Given this list of marker genes GALE, IDH2, PPP1R3A, GALK2, SORD, GCNT3, PARG, NR0B1 (nuclear receptor subfamily 0 group B member 1), LRP5, SIK1, ENO1, PPP1R2P1, IDUA, TCF7L2, AVPR1B, IL6ST, SIRT1 (NCBI Gene Id 23411), MAN2C1, GALNT7, PPP4R3A, JMJD8, C1QTNF1, ATF3, PMM2, ERRFI1, PGAM4, NCOR1, LCT (lactase), PGM5, FLCN, PYGM, GSK3A, TREX1, APOD, PPARA, PFKFB1, GCK, GCKR, IDH3G, TGFB1, FBN1, SDS, DDB1, RPEL1, GLB1L3, POFUT2, GSK3B (glycogen synthase kinase 3 beta), MANBA, RORA, SDHAF3, EXT1 (NCBI Gene Id 3966), APP, CBFA2T3, ST3GAL6, ENO4, LCTL, HYAL1, B4GALT4, TFF3, ABO, PGM3, DHDH, GAL3ST3, SI, P2RX7, OVGP1, GMPPB, PFKFB4, SLC4A4, DHTKD1, MGAM, GYG2, PHKB, ERFE, ARPP19, LCMT1, PHKG2, NTSR1, B4GALT6, HEXD, ATG12, WDR45, PDHA1, BCKDK, MPI, C1QTNF3, PIGQ (NCBI Gene Id 9091), MIR103A1, PARP1, MLYCD, NR1D1, NAGPA, INPPL1, GPLD1, CHST7, ST6GALNAC5, HEXA, EIF6, HK1, PFKP, SLC2A8, GRB10, BPGM, UGP2, CD244, CHST15, PCK2, B3GALT5, AKT2, MDH2, SERPINA12, IGF1, G6PC3, SORBS1, SLC35B4, HK2, PER2, HTR2A, IRS1, FUT3, B3GALT4, TPD52L2, IER3, SLC5A2, ADCY10, NUPR1 (NCBI Gene Id 26471), FUT5, LEP, SLC3A1, PPP1CC, IDH3A, PGM2, MAN2B1, CHST2, PPP1CB, FUT6 (fucosyltransferase 6), P2RY6, ST8SIA2, C1QTNF12, ACACB, FAM3A, SLC23A2, GBGT1, MAN2A2, NAGK, PDHA2, ATF4, PPP1R3E, UXS1, PPP1R3F, EDEM2, B3GAT2, PLEK, DDIT4, NEU3, HAS1, GSTO1, GALT, RORC, ST3GAL4, CLK2, MYORG (myogenesis regulating glycosidase), AMY2A, STBD1, FUT10, ERO1A, SLC25A11, MIDN, FCSK, STAT3, PPP1R3D, CHI3L2, NCOA2, MIR195, XYLB, SLC2A3, MLXIPL, TFAP2B, AKR7A2, PFKFB2, ST3GAL2, SLC2A4, TRIM63, EDEM1, ALDH2, EDEM3, SLC2A2, BOLA3, HYAL4 (NCBI Gene Id 23553), COQ2, SLC25A13, LANCL1, PHLDA2, PYGB, ADIPOR1, ALDOB, GHRL, SLC3A2 (NCBI Gene Id 6520), G6PC1, ENO2, GAA, WDTC1, IGFBP4, LHCGR, TP53, DCXR, SLC35A2, RBP4, PDHB, MAN1A1, B4GALT2, GAPDHS, SCARB2, PPP1R2, HKDC1, GLB1L2, TPI1, BAD, GLA, B3GALT1, ST8SIA3, ST6GALNAC3, PTPN2, GANAB, PKM, RANBP2, KAT2A, NEU2, FOXO1, GDPGP1, PGAM2, GCLC, POMC, MTCH2, KAT2B, INPP5K, PLA2G4A, CHST6, G6PC2, MOGAT2, PFKL, MAN2A1, ALDOA, BRS3, PSEN1 (presenilin 1), KLB, H6PD, MOGS, NLN, CLSTN3, NNMT, PRKN, PRKAG3, GNE, DLAT, B4GALT7, SERP1, UCHL1, RB1CC1 (RB1 inducible coiled-coil 1), GYG1, LANCL2, ZMPSTE24, PGM1, ST3GAL3, FKRP, RPTOR, PGK1 (phosphoglycerate kinase 1), ALDH1B1, GAL3ST4, ST8SIA6 (NCBI Gene Id 338596), PDK3, GLB1L, GYS1, HEXB, DYRK2, ENO3, ATG3, CHST10, PTH1R, FOXK1, ADCYAP1R1, MAN2B2, GM2A, GAPDH, CHST9, ACTN3, CHST8, INSR, TNF, FABP5, FOXK2, UCP2, MIR1271, TALDO1, GNPDA2, GCNT4, PPP1CA, SLC2A6, POMK, PGLS, SLC2A1, ENPP1, PPP1R3G, GPD2, SPATA20, SRC, TREH, PCDH12, NR3C1, EP300, FBP1, ST8SIA1, PYGL, PHKA2, CASD1, MIR107, FUT7, RENBP (renin binding protein), MGAT2, ZFP92, GLB1, OTOG, PPP1R2B, RPIA, PASK, GCG, KCNJ11, PDK4, PFKFB3, SIAE (sialic acid acetylesterase, NCBI Gene Id 95985), B4GALNT1, B3GLCT, NAGA, TFF1, SLC37A4, PKLR, IGF2, ACADM, NFE2L1 (NFE2 like bZIP transcription factor 1), GK2, HK3, POFUT1, CHST4, GLO1, PRKACA, LEPR, EPM2A, HDAC4, PC, SIRT7, CRY1, TKTL1, FPGT, NHLRC1, MTOR, SESN2, PCK1, GALNT3, B4GALNT2, CLTC, CTBS, MAN1C1, CHST1, PIK3CA, SLC35A1, USF1, BCL2L13, CS, IGFBP3, PGAM1, ATG2B, IDNK, GPD1, ANGPTL3, PTH (parathyroid hormone), OGT, MOGAT3, FUT9, KCNQ1, HSD17B14, PPARD, CHIT1, FUT4, SLC4A1, SLC45A3, MLST8, RBKS, PFKM, DGAT2, GPER1, GNMT, PPP1R3C, PGK2, ATP1A2, GOT1, GSTO2, KBTBD2, TIGAR, CHST13, FUT1, ME1, SLC23A1, STK40, AMY1C, ST8SIA5, ST6GAL2, MST1, ADIPOQ, EXT2, NFKB1, NEU4, ST6GALNAC1, GIT1, AGL, ARNT, KHK, GNPTG, PDX1, YDJC, A4GNT (alpha-1,4-N-acetylglucosaminyltransferase), PGGHG, PRKAG2, RPE, AKT1, HYAL2, NPY1R, GPD1L, GALM, B3GAT1, PDK1, B4GALT1, GYS2, HAS3, GBE1, AMY1B, CHIA, GNPTAB, CRTC2, ATG2A, NPL, SLC2A5, FUCA2, PPP1R1A (protein phosphatase 1 regulatory inhibitor subunit 1A), NDST1, ADRB3 (adrenoceptor beta 3), SNCA, GABARAPL1, SLC25A10, PGD, GLT6D1, PPP4R3B, EPM2AIP1, AKR1B1, ST6GALNAC6, CHID1, P2RY1, HIF1A, FGGY, PPP1R3B, PGM2L1, MPDU1, PRKAA2, B3GALT2, GNPDA1, PRKAA1, MAN1B1, A3GALT2, TKFC, IFNG, BRAT1, LANCL3, PRXL2C (NCBI Gene Id 203335), ST6GALNAC4, PMAIP1, GUSB, SMPD3, MAN1A2, NPC1, PRKAG1, FUCA1, G6PD, USP7, SELENOS, PRKG1, SELENON, NANS, MFSD8, WDR45B, ENOSF1, B3GAT3, FUT2, OGDHL, PPARGC1A, CHST12, LIPA, PMM1, ST8SIA4, HYAL3, WDR5, COMT, ONECUT1, WIPI1, SHPK, LDHA, CHST14, OTOGL, GK5, GCGR, CHST3, ZBTB20, GANC, GALK1, MTCL2, MOGAT1, ADPGK (ADP dependent glucokinase), OMA1, MIR15B, B4GALT3, GLYCTK, ZBTB7A, ZNF692, HAS2, RUBCNL, AMY1A, IDH1, GK (NCBI Gene Id 2710), CPT1A, WIPI2, NUDT5, FBP2, HMGB1, MGAM2, IRS2, PDGFB, OGDH, PHKA1, OAS1, FUT8, PHKG1 (phosphorylase kinase catalytic subunit gamma 1), B4GALT5, MAPK14, CHI3L1, GBA2 (glucosylceramidase beta 2), COL6A1, PPP2CA, FUOM, CHST5, INS, PDK2, DERA, KL (NCBI Gene Id 9365), GPI, COQ3, LALBA, ARL2, GNB3, AMY2B, SIRT6, CHST11, PGP, EGF, HECTD4, SPAM1 (sperm adhesion molecule 1), SLC39A14, MIR210 (microRNA 210), GBA3, NEU1, B3GALNT1, ALDOC, AP2A1, DGKQ, here is a description of the gene set: Human Gene Set: GOBP_CARBOHYDRATE_METABOLIC_PROCESS The chemical reactions and pathways involving carbohydrates, any of a group of organic compounds based of the general formula Cx(H2O)y. species: Homo sapiens